The following is a description of a gene set: species: Mus musculus part of: Signal Transduction Reactome Pathway: Signaling by Hedgehog This event has been computationally inferred from an event that has been demonstrated in another species.<p>The inference is based on the homology mapping from PANTHER. Briefly, reactions for which all involved PhysicalEntities (in input, output and catalyst) have a mapped orthologue/paralogue (for complexes at least 75% of components must have a mapping) are inferred to the other species. electronically inferred by orthology from the curated human pathway, and this is the list of marker genes: P4hb (NCBI Gene Id 18453), Prkar2b, Gli3, Fuz, Psmc1, Tuba1c, Psmd1, Prkacb, Tubb2b, Tubb4a, Psmc2, Tubb6, Sel1l, Ttc21b, Smo, Vcp, Ihh, Numb, Psmc3, Psma5, Tubb4b, Psma6, Ubb, Tuba3b, Psmb7, Psmb6 (NCBI Gene Id 19175), Ift172, Psma3, Csnk1a1, Arrb2, Psmd7, Notum, Adcy7, Adcy5, Psmc6, Erlec1, Psma7, Tuba1a, Tuba4a, Psma1, Ift57 (intraflagellar transport 57), Tuba1b, Hhat, Adcy8, Cul1, Gpr161, Psmd6, Smurf1, Spop, Prkar1b, Ulk3, Prkaca, Evc2, Psmb4, Mks1, Shh, Evc, Rps27a, Gas1 (growth arrest specific 1), Psmd13, Smurf2, Psmd12, Psmb5, Psmc5, Ift88, Wdr35, Psma2, Psma4, Psmc4, Cdon